Given this list of marker genes IPO7, RAN, RANBP2, TNPO2, NUP107, NUP153, CLIC1, SUMO1, NUP88 (NCBI Gene Id 4927), TMPO, KPNB1, TNPO1, KPNA1, CSE1L, XPO1, SNUPN, TPR, here is a description of the gene set: Human Gene Set: MODULE_352 Nuclear pore complex. studied in species Homo sapiens